Given this list of marker genes MIR208A, P2RX1, AKAP5, MS4A1, PRNP, KCNN4, PPP3CB, PPP3CC, GRM6, PPP3R2, P2RX5, MIR200C, FYN, PPP3R1, MIR208B, PPP3CA, here is a description of the gene set: Human Gene Set: GOBP_REGULATION_OF_CALCIUM_ION_IMPORT_ACROSS_PLASMA_MEMBRANE Any process that modulates the frequency, rate or extent of calcium ion import across plasma membrane. species: Homo sapiens